The following is a description of a gene set: Regulatory T (Treg) cells that express the FoxP3 transcription factor are essential for lymphoid homeostasis and immune tolerance to self. Other non-immunological functions of Treg cells, such as controlling metabolic function in adipose tissue, are also emerging. Treg cells originate primarily in the thymus, but can also be elicited from conventional T cells by in vivo exposure to low-dose antigen or homeostatic expansion, or by activation in the presence of TGFβ in vitro. Treg cells are characterized by a distinct transcriptional signature controlled in part, but not solely, by FoxP3. For a better perspective on transcriptional control in Treg cells, we compared gene expression profiles of a broad panel of Treg cells from various origins or anatomical locations. Treg cells generated by different means form different sub-phenotypes identifiable by particular combinations of transcripts, none of which fully encompass the entire Treg signature. Molecules involved in Treg effector function, chemokine receptors, and the transcription factors that control them are differentially represented in these subphenotypes. Treg cells from the gut proved dissimilar to cells elicited by exposure to TGFβ, but instead they resembled a CD103+Klrg1+ subphenotype preferentially generated in response to lymphopenia. species: Homo sapiens from publication Feuerer M, Hill JA, Kretschmer K, von Boehmer H, Mathis D, Benoist C (PMID 20231436) Genes up-regulated in comparison of TregCD103-Klrg1- versus TregCD103+Klrg1+ (see Table 1S in the paper for details). Human Gene Set: GSE20366_CD103_KLRG1_DP_VS_DN_TREG_UP, and this is the list of marker genes: MCF2L, GUCY1B1, ABHD17C, NUP188, POLG2, RPL12, AOC3, THEM4, GABRR2, DHCR24, UTP25, DNAJC6, PIK3C2G, ASAP1, ISOC1, FCGR1A, GPR152, DIP2C, ZNF512, IGLON5, EXOC6, SNRNP70, WFIKKN2, FASTK, FRYL, F8, CALHM6, CDC40, PWP1, HTATSF1, RCC2, KRT14, AQP7, TMEM41A, SH3BP1, MYC, TECTB, EXTL1, MTG1, SLC26A8, IGF2R, EBF3, LYSMD2, PTPRF, TRMT112 (tRNA methyltransferase activator subunit 11-2), TMEM151B, RASL11A, NGF, TASP1, ENO3, PHF21A, PHYHIP, KNOP1, CCDC146, PPP2R5B, C6orf132, CRYBG1, METTL13, SLC39A14, WNT3, SCGB3A1, POLR2H, SPRED3, ADAM7, SLC7A3, KANK2 (NCBI Gene Id 55598), ITIH5, SLC6A7, NUP93, NAT14, LRRC8D, WWC1, SEMA7A, CFAP157 (cilia and flagella associated protein 157), CDH20, LRIG1, ARRB2, C19orf48P, ID3, LCAT, PCBP1, ZNF397, MAGOH, ICE2, STOX2, LRRC46, CTU1, CSTF2T, PPP2R2C, TMEM205 (NCBI Gene Id 90585), HDGF, PKD1, EEIG1, KCNJ2, PDLIM1 (PDZ and LIM domain 1), FAM120AOS, GPR83, RCN1, ACER2, RPL30, SRCAP, CCDC171, RAB3IP, ST6GALNAC5, RETREG3, CDH2, TIMM9, TMEM245, THRB, ARMCX2, DHX58, RTF1, C1orf185, ZNF827, UBQLN4, DDX11, DRAM2, HDAC2, EXOSC2, MDN1, KRT24, SCNN1B, MCOLN3, CHL1, ARHGEF9, SLC22A5, MVK, MTR, NOP10 (NOP10 ribonucleoprotein), AFF1, TCF23, TMTC4, NKTR, SOCS3, FOXO1, KRTAP8-1, AKR1C3, IMMP2L, AGER, CERCAM, ARHGEF10, TMPRSS11A, TSACC, AKAP5, KCNH2, MAGI3, C1orf53, RSPH6A, RHAG, PHIP, RAB9B, ARL13A, RASA1, POLR3D, METTL18, MYRFL (NCBI Gene Id 404282), RYR2, MAPK12, RPS7, KIAA1217, MDC1, SELL, STAMBPL1, TRIP10, DNAH12, AKAP3, TBC1D22B, XYLT2, RCN2, HDAC4, CRYM, PRMT3, PILRA, TMEM70, ZFP37, CCDC22, CASP8, SPRY1, NTSR2, NETO1, ROR2, RASSF5, ZNF420, METTL1, CDYL2, EPB41L5, CD2AP (NCBI Gene Id 25916), LARP4, CCNDBP1, FAM170A (NCBI Gene Id 340069), IFIT3, HILPDA, PIGP, TMEM179, SLCO4C1, RPL31, CHCHD10, SGPP1, CRY2